The following is a description of a gene set: studied in species Mus musculus Mouse Gene Set: REACTOME_INSULIN_RECEPTOR_RECYCLING Insulin receptor recycling, and this is the list of marker genes: Atp6v0e (ATPase, H+ transporting, lysosomal V0 subunit E), Ptpn1, Atp6v0a1 (ATPase, H+ transporting, lysosomal V0 subunit A1), Atp6v1c1, Ctsd (NCBI Gene Id 13033), Atp6v1g2, Atp6v1g1, Atp6v1h, Atp6v0d2, Atp6v1e2, Atp6ap1, Atp6v0d1, Tcirg1, Atp6v0b, Atp6v1f, Atp6v1e1, Atp6v1b2, Ins1, Atp6v1g3, Atp6v1c2, Ide, Atp6v1d, Atp6v0c, Atp6v0a4, Ptprf, Atp6v0a2, Insr, Atp6v1a, Atp6v1b1, Atp6v0e2